Given this list of marker genes TUBA1B, TUBB6, TUBA3D, TUBB4B, TUBB3, ROCK1, ROCK2, RHOA, TUBA1A (tubulin alpha 1a), TUBB2A, ARHGEF2, TUBA8, TUBB2B, TUBB1, TUBB4A, TUBA1C, TUBA3E, TUBA4A, TUBB, TUBA3C, TUBB8, here is a description of the gene set: studied in species Homo sapiens Microtubule-RHOA signaling pathway. Pathway ID: N01285. Pathway type: Reference. Pathway class: nt06135 Cytoskeletal regulation (viruses and bacteria). Pathway Definition from KEGG: (TUBA+TUBB) -| ARHGEF2 -> RHOA -> ROCK1/2 Human Gene Set: KEGG_MEDICUS_REFERENCE_MICROTUBULE_RHOA_SIGNALING_PATHWAY